The following is a description of a gene set: Mouse Gene Set: GOBP_RESPONSE_TO_REACTIVE_OXYGEN_SPECIES studied in species Mus musculus Any process that results in a change in state or activity of a cell or an organism (in terms of movement, secretion, enzyme production, gene expression, etc.) as a result of a reactive oxygen species stimulus. Reactive oxygen species include singlet oxygen, superoxide, and oxygen free radicals., and this is the list of marker genes: Setx, mt-Nd5, Cryaa, Fchsd1, Slc8a1, Prdx6, Aldh3a2, Col6a1, Gstp1 (NCBI Gene Id 14870), Trpc6, Ucp1, Trap1, Akt1, Hif1a, Sdc1, Prkca, Ppp2cb, Nos3, Park7, Prkaa1, Pex10, Aifm1, Fkbp1b, Zfp580, Il6, Rnf146, Casp6, Plk3, Casp3, Gch1, Foxp1, Pex12, Sirt1, Nme8, Cryab (crystallin, alpha B), Ucp3, Ptprn, Capn2, Sirpa, Txn1, Kdm6b, mt-Nd6, Scgb1a1, Adam9, Prdx1, Pdk2, Rlig1, Mdm2, Anxa1, Ezh2, Dhfr, Adcyap1r1 (NCBI Gene Id 72954), Rps3, Mb, Nudt15 (NCBI Gene Id 214254), Mmp9, Star, Mapk7, Cryge, Ddr2, Sod1, Crk, Endog, Sesn1, Gpx1, Egfr, Foxo1, Map3k5, Hmox1, Zfp277, Becn1, Mapk3, Pex5, Prkcd, Fabp1, Ppef2, Cd36, Cbx8, Lrrk2, Pdgfra, Nox1, Klf2, Prdx2, Stat6, Hk3, Mapk9, Il1a (NCBI Gene Id 16175), Mmp3, Klf4, Abcc9, Trp53, Gpr37l1, Bak1, Jun, Trpm2, Top2b, Pex2, Agap3, Nme5, Pcgf2, Ccs, Kpna4, Pcna, Ube3a, Hyal1, Ednra (endothelin receptor type A), Sesn3, Cyp11a1, Ercc6, Atg7, Fancc, Ngb, Fosl1, Crygf, Nfe2l2, Gpr37, Coa8, Txndc2, Gja3, Plekha1, Met, Foxo3, Ep300, Map1lc3a, Fxn, Trex1, Apod, Axl, Hspa8, Hsf1, Rela, Mapk8, Fer, Smpd3, Txnip, Tnfaip3, Sirt6, Akr1b1, Edn1, Cat, Chuk, Net1, Stk25, Sod3, Aqp1, Ripk1, Sesn2, Pjvk, Il18rap (interleukin 18 receptor accessory protein), Nqo1, Prdx5, Oser1, Foxa1, Ect2, Ppp1r15b, Ogg1, Psap, Ern1, Mt3, Sphk1, Lck, Cdkn2a, Kcna5, Bnip3, Hyal2, Rack1, Hgf, Fyn, Btk, Src, Abl1, Rhob, Nr4a3, Romo1, Pawr, Pex13, Pdcd10, Mpo, Mmp2, Crygd, Tacr1, Ptprk, Adprs, Tet1, Col1a1, Trpa1, Lcn2, Pdgfd, Atp7a (NCBI Gene Id 51824), Bcl2, Pdgfrb, Ankzf1, Prdx3, Mpv17, Areg, Atm, Ucp2, Ppif, Epor, Cyp1b1, Ppargc1b, Hdac2, Sod2, Pink1, Map2k4, Ripk3, Hdac6, Slc4a1, Cfl1, Capn1, Ambp, Fos, Mapk13, Apoa4, Fbln5, Parp1, Ptk2b, Ercc6l2, Cygb, Cdk1, Gata5, Apex1, Txnrd2, Pex14, Lig1, Mapk1, Pld2